The following is a description of a gene set: Mouse Gene Set: GOBP_REGULATION_OF_NEURON_MATURATION studied in species Mus musculus Any process that modulates the frequency, rate or extent of neuron maturation, the process leading to the attainment of the full functional capacity of a neuron. This process is independent of morphogenetic change., and this is the list of marker genes: Ret, Ngf, Bcl11a (BCL11 transcription factor A), Lrrk2, Dleu2, Tbx6, Mir133b (NCBI Gene Id 723817), Mtor, Nox1, Grip2, Bcl2, Mir212, Ednrb, Mir132 (microRNA 132), Rac3, Opa1, Map3k13, Rac1, Gsk3b